The following is a description of a gene set: Mouse Gene Set: MP_INCREASED_HEMOLYMPHOID_SYSTEM_TUMOR_INCIDENCE from publication Motenko H, Neuhauser SB, O'Keefe M, Richardson JE (PMID 26092688) Mouse genes annotated to increased hemolymphoid system tumor incidence (MP:0010296) retrieved from the Mouse Genome Informatics database via MouseMine studied in species Mus musculus, and this is the list of marker genes: Msh6, Dicer1, Jak2, Crebbp, Mir146 (microRNA 146)